The following is a description of a gene set: Human Gene Set: MATSUMIYA_BLOOD_MODIFIED_VACCINIA_ANKARA_VACCINE_AGE_4_6MO_VACCINATED_VS_CANDIN_PLACEBO_BCG_PRIMED_1DY_UP BACKGROUND: Tuberculosis (TB) remains a global health problem, with vaccination likely to be a necessary part of a successful control strategy. Results of the first Phase 2b efficacy trial of a candidate vaccine, MVA85A, evaluated in BCG-vaccinated infants were published last year. Although no improvement in efficacy above BCG alone was seen, cryopreserved samples from this trial provide an opportunity to study the immune response to vaccination in this population. METHODS: We investigated blood samples taken before vaccination (baseline) and one and 28 days post-vaccination with MVA85A or placebo (Candin). The IFN-gamma ELISpot assay was performed at baseline and on day 28 to quantify the adaptive response to Ag85A peptides. Gene expression analysis was performed at all three timepoints to identify early gene signatures predictive of the magnitude of the subsequent adaptive T cell response using the significance analysis of microarrays (SAM) statistical package and gene set enrichment analysis. RESULTS: One day post-MVA85A, there is an induction of inflammatory pathways compared to placebo samples. Modules associated with myeloid cells and inflammation pre- and one day post-MVA85A correlate with a higher IFN-gamma ELISpot response post-vaccination. By contrast, previous work done in UK adults shows early inflammation in this population is not associated with a strong T cell response but that induction of regulatory pathways inversely correlates with the magnitude of the T cell response. This may be indicative of important mechanistic differences in how T cell responses develop in these two populations following vaccination with MVA85A. CONCLUSION: The results suggest the capacity of MVA85A to induce a strong innate response is key to the initiation of an adaptive immune response in South African infants but induction of regulatory pathways may be more important in UK adults. Understanding differences in immune response to vaccination between populations is likely to be an important aspect of developing successful vaccines and vaccination strategies. TRIAL: ClinicalTrials.gov number NCT00953927. from publication Matsumiya M, Harris SA, Satti I, Stockdale L, Tanner R, O'Shea MK, Tameris M, Mahomed H, Hatherill M, Scriba TJ, Hanekom WA, McShane H, Fletcher HA (PMID 24912498) Genes up-regulated in blood vaccinated vs candin placebo in infants (4-6m) (BCG-primed) after exposure to Modified Vaccinia Ankara (MVA) virus vaccine vector, time point 1D studied in species Homo sapiens, and this is the list of marker genes: UBE2L6, CASP4, IDO1, MT1G, CALHM6, POMP, XRN1 (5'-3' exoribonuclease 1), PARP9, MRPL44, CARD17P, CASP1, ETV7, ANKRD22, GBP5, CXCL10